Given this list of marker genes PCYT2, PTPRE, LHFPL2, DNAJB4, GRAMD4, TJP2, CTBP2, SPRED2, SRP68, GTPBP4, ZNF638, MDP1, SACM1L, HEATR1, ADO, TBC1D10A, FAR1, FTSJ3, SYNCRIP, TMEM37, PIK3CA, ZC3H18, SUCO, KCNK13, UBE2G2, RNF2, DAPK1, QTRT2, TBC1D2B, ZSWIM4, PALS1 (NCBI Gene Id 64398), NBEAL2, SGSM3, PANK3, FUBP1, HM13, NPTN, MRPL36, PTGER2, HGF, RSBN1, TRAM1L1, EIF3A, MSMO1, IBTK, UBE2G1, TMEM42, USP16, RLIM, FOXN2, ALG5, WDR91, SNX25, PABPN1, NFE2L2, LATS2, GIT2, PWP2, PHF2 (NCBI Gene Id 79448), DDX23, TBC1D12, GCNT1, AGAP1, ANKRD44, CNNM2, KAT6B, GLUL, PPRC1, IFNGR1, EIF3J, ARID1B, DDX21, RAP2B, GRWD1, POLR3E, FNBP1, RRS1, TMEM135, RALGPS1, PAN3, EIF4G1, PALD1, NBEAL1, ATP13A3, SP1, RGL2, DDX27, TRMT61A, ZMYND19, CAND1, USP24, VDR, IPO7, RDH13, ZMYM2, OPHN1, CCNT1, INPP5D, SPPL3, OTULINL, YPEL2, TMEM70, ERCC6, MTF2 (NCBI Gene Id 22823), CRAMP1, HSPA13, ACTG1, ST6GAL1, DIP2B, MICAL2, PRKAG2, PDE3B, G3BP1, ARL6IP6, TPCN2, EMC6, CHML, B3GNT8, PUS3, CSTA, PUS1, MEF2A, MTSS1, SIN3A, INPP5A, PUS7 (NCBI Gene Id 54517), SBNO1, MACO1, ATP7A, ZFHX3, URB1, ADCY9, RNF19A, REPS2, CCDC9, ZDHHC14, MAFG, CERK, MICALL1, IPO5, ROCK2, GNL2, ANKRD11, NLE1, DDX51, EIF1B, SLC20A1, NOP56, EEF1G, RABEP1, PKD2, WWP1, TCERG1, IRF4, WWC2, EIF2AK4, RRP1B, MAP3K2, C5AR2, NUP54, NOP58, PUM1, SGMS1, ATXN3, SLC35E1 (solute carrier family 35 member E1), NCOR2, SMAD3, BRWD1, SLC27A4, PLCG1, AMPD3 (NCBI Gene Id 272), NOC3L, NOP2, AGFG2, TXNL1, FOXJ3, BIN1, CD151, SNX8, THAP6, USP53, here is a description of the gene set: Genes up-regulated in macrophages in response to LPS: naïve versus tolerant. The inflammatory response initiated by microbial products signaling through Toll-like receptors (TLRs) of the innate immune system is essential for host defense against infection. Because inflammation can be harmful to host tissues, the innate response is highly regulated. Negative regulation of TLR4, the receptor for bacterial lipopolysaccharide (LPS), results in LPS tolerance, defined as hyporesponsiveness to repeated stimulation with LPS. LPS tolerance is thought to protect the host from excessive inflammation by turning off TLR4 signal, which then shuts down TLR-induced genes. However, TLR signaling induces hundreds of genes with very different functions. We reasoned that genes with different functions should have different requirements for regulation. Specifically, genes encoding proinflammatory mediators should be transiently inactivated to limit tissue damage, while genes encoding antimicrobial effectors, which directly target pathogens, should remain inducible in tolerant cells to protect the host from infection. Using an in vitro system of LPS tolerance in macrophages, here we show that TLR-induced genes may indeed be divided into two distinct categories based on their functions and regulatory requirements. Further, we show these distinct groups are regulated by gene-specific, and not signal-specific mechanisms. from publication Foster SL, Hargreaves DC, Medzhitov R (PMID 17538624) Human Gene Set: GSE7348_LPS_VS_TOLERIZED_AND_LPS_STIM_MACROPHAGE_UP species: Homo sapiens